Given this list of marker genes IL10, BAG6, OPHN1, ALAD, RELA, USP14, PSMF1, PABPN1L, LAMP3, DAB2IP, MDM4, PANO1, MAP1A, SGTA, CCAR2, AZIN2, MAD2L2, ARHGAP5-AS1, RIC1, SENP1, OGT, MGAT3 (NCBI Gene Id 4248), FMN2, FHIT, TMEM132A, USP25, USP5, SF3B3, GIPC1, TIMP3, AQP11 (NCBI Gene Id 282679), SHH, PBK (PDZ binding kinase), TIMP2, TRIM40, CAMLG (NCBI Gene Id 819), SNX3, CSNK2A1, DDRGK1, MIR128-1, FLNA (filamin A), TAF9, ROCK1, USP9X, EGFR, USP7, TTC36, F8A1, NOS2, TIMP4, SVIP, USP26, F8A3, KLHL40, CSNK2A2, PSME3IP1, GRIN2C, SERPINB12, GABARAPL2 (GABA type A receptor associated protein like 2), ATP13A2, SMARCC1, DEDD, SNX12, UCHL5, LAPTM4B, PHB1, FURIN, SMAD3, GRIN2A, IRAK3, PHF20L1, USP38, CTSA, PRKCG, CSNK2B, TRIM39, FYN, TIMP1, SMAD4, VPS35, CST3, HSP90AB1, PTPN3, CYP51A1, RGP1, INS, NOP53, HFE, SNRNP70, PIN1 (peptidylprolyl cis/trans isomerase, NIMA-interacting 1), AGAP2, RPL11, NQO1, USP8, N4BP1, CDK5RAP3, AZIN1, PARK7, HMGCR, SIRT2, SNCA, MYCBP2, MARCHF7, RYBP, UBXN1, ATRAID, UBXN2A, F8A2, MTM1, ADGRB1, TLK2, STYX, BAG5, EIF3H, WAC, RILP, LRIG2, NELL1, SERPINE2, MAD2L1, ANXA2, here is a description of the gene set: studied in species Homo sapiens Human Gene Set: GOBP_NEGATIVE_REGULATION_OF_PROTEIN_CATABOLIC_PROCESS Any process that stops, prevents or reduces the frequency, rate or extent of protein catabolic process.